The following is a description of a gene set: Human Gene Set: HP_ORTHOSTATIC_HYPOTENSION studied in species Homo sapiens A form of hypotension characterized by a sudden fall in blood pressure that occurs when a person assumes a standing position. Orthostatic hypotension, and this is the list of marker genes: LMNB1, COL1A1, HEXB, SNCA, GMPPA, LRRK2, SPIB, SAA1, GBE1, CAV1, CHCHD2, GBA1, EIF4G1, ELP1, VPS35, ACBD6, TNFSF15, LEPR, ARSA, POU2AF1, GSN, CYB561 (cytochrome b561), IRF5, TNPO3 (NCBI Gene Id 404679), SPG11 (NCBI Gene Id 80208), GIGYF2, ATP7A, CHRNA3, TTR, B2M, COL5A1, MMEL1 (membrane metalloendopeptidase like 1), AAAS, LEP, CYP11B2, DBH, COQ2, PSAP, IL12A, IL12RB1, SIM1, COL5A2, DNAJC13 (NCBI Gene Id 285196), NTRK1